The following is a description of a gene set: Genes predicted to be targets of miRBase v22 microRNA hsa-miR-6860 in miRDB v6.0 with MirTarget v4 prediction scores > 80 (high confidence targets). from publication Chen Y, Wang X (PMID 31504780) studied in species Homo sapiens Human Gene Set: MIR6860, and this is the list of marker genes: CXXC4, CCP110, CEACAM7, PPP2R2B, PRND, ARRDC3, HIVEP3, TPI1, TFAP2A, TRMT13, BTRC, NXF1, WNT4, AKAP13, KDM2B, SIDT1, GIPC3, KCNB1, NDOR1, PLOD1, RPL28, IFT122, PRR14L, RAB11FIP3, SAR1A, SLC6A4, GRK6, NUDT19, H6PD, LRRC31, APPBP2, IPO9, FGF14, DDX11 (NCBI Gene Id 93260), TMEM41B, ATP8A1, GAB2, TCTN3, DAB2IP, RC3H1, PPP3CB, ARF6, COL4A5, NF2, GPI, SSH2, APBB2, FMOD, PTGES3L, RARB, CREB5, TMEM127, YTHDF1, GABRA1, TANGO2, SRFBP1, PLEKHM1, RD3, NECTIN1, CHL1, HOXA13, NOS1, ABCB8, SMAD6, ARNT2, PHF21A, RMI1, PTEN, PSD3, SLC25A12, SEC63 (SEC63 homolog, protein translocation regulator), NRP1, SMPD1 (sphingomyelin phosphodiesterase 1), FBXO33, TRABD2B, SPRTN, NUFIP2, LARP1, CMTR2, RYBP, MARCKSL1, ZNHIT6, AHI1, DCTN5, CMKLR1, YAP1, SEC14L1 (NCBI Gene Id 6397), CCNT1, CRTC1, RBMS2, FMO5, FAM120C, SRR, LRRC41, LRRTM3, ZBTB8B, GDNF, SIKE1, NLRP14, CKAP4, GPR62, KCNK2, JRK, FOXP4, ZNF322, C1orf210, ACP6